Given this list of marker genes Gja5, Gja1, Panx2, Panx1, Panx3, Gja6, Gja3, here is a description of the gene set: Mouse Gene Set: GOMF_GAP_JUNCTION_HEMI_CHANNEL_ACTIVITY species: Mus musculus A wide pore channel activity that enables the transport of a solute across a membrane via a gap junction hemi-channel. Two gap junction hemi-channels coupled together form a complete gap junction.